Given this list of marker genes APOF, MRPL39, EIF3I, SHMT1, ANO10, MCC, TMEM255A, DEF8, NCAPD2, CD160, FAM111A, ERBB3, SAMD14, BABAM1, CHSY1, DSC1 (NCBI Gene Id 1823), GJB3 (gap junction protein beta 3), CHAF1B, DAPL1, TOPBP1, GFAP, DBNL, MCRIP2, ANAPC15, NRIP3, WDR90, TMEM131, MSRB1, RAB33A, RASAL1, LAMP5, PRDX2, KLHL9, CCDC50, E2F1, NDUFAF2, H2AC15, RS1, RPS8, DTL, ATP5MC1, TRAPPC4, CFAP95, BCL2L2, SDHB, NPM1, PFKL, RNASEH2C, PRELID2, KIF11 (NCBI Gene Id 3832), POLR2F, TOMM7 (translocase of outer mitochondrial membrane 7), PDIA3, SNRPE, NAPA, MAPK11, ANGPTL2, C2CD5, RNF26 (NCBI Gene Id 79102), FUBP3, H2BC3, IFNE, SNAI1, CHPF, RASL11B, MCM5, MITF, ASIC1, ATP5MC2, POLA2, COTL1, UNG (NCBI Gene Id 7374, uracil DNA glycosylase), SGTA, RHD, PGM2, KCTD13, COX7A2, LSM3, CAD, SLC25A39, UBASH3A, RASGEF1B, MRPL23, CSTF1, XXYLT1, DKC1, POLR2E, H2BC26, ANKLE1, TMEM147, E2F4, MIR155, BCL2L13, ANXA5, CALM3, C7orf50, MXD3, RAB18, NDUFA8, SF3B3, RTL6, PTPN6 (NCBI Gene Id 5777), INTS3, MED22, TOR1A, PSME3 (NCBI Gene Id 10197), EIF3L, CASP8AP2, H4C8, CENPM (centromere protein M), SMYD2, AP2M1, DYNLT2B, PPME1, MTAP, GFUS, SUZ12, TMPO, GPAT4, RPL36, RGS1, SYCE2, GDF11, LITAF, IRAG2, DUBR, TUBG2, MECR, NT5C, LRATD1, RNF187, ALG8, ARFIP2, ZMAT5, SMIM12, SLC2A1, GYPC, PPP4C, CDPF1, TXNDC12, PRR3, UNC13A (unc-13 homolog A), DHX33, GRPEL1, CINP (cyclin dependent kinase 2 interacting protein), SNAPC2, TNFRSF9, FAM135A, FANCA, ATP5F1E, HPRT1 (hypoxanthine phosphoribosyltransferase 1), SGSM3, UTP4, ANXA6, COPS9, ALKBH7, DNMT3A, MCM7 (NCBI Gene Id 4176), TIAM1, DAP3, DNAJC22, PRIM1, MRPS17, TM9SF3, TBL3, ZGRF1, PRCC, PPIC, DYNLL1, VHL, PDXK, here is a description of the gene set: Human Gene Set: GSE15624_CTRL_VS_3H_HALOFUGINONE_TREATED_CD4_TCELL_DN from publication Sundrud MS, Koralov SB, Feuerer M, Calado DP, Kozhaya AE, Rhule-Smith A, Lefebvre RE, Unutmaz D, Mazitschek R, Waldner H, Whitman M, Keller T, Rao A (PMID 19498172) Genes down-regulated in CD4 T cells: control versus treated with halofuginone for 3h. studied in species Homo sapiens T cell differentiation to the Th17 effector subset requires stimulation through the T cell and co-stimulatory receptors, together with cytokine stimulation by TGFb and IL-6. The small molecule halofuginone (HF) inhibits Th17 cell development and induces a pattern of stress-regulated gene expression that mimics amino acid starvation. We used global transcript profiling to ask how halofuginone modulates gene expression induced during T cell activaiton and Th17 differentiation